The following is a description of a gene set: studied in species Homo sapiens Catalysis of the reaction: carbohydrate phosphate + H2O = carbohydrate + phosphate. Human Gene Set: GOMF_CARBOHYDRATE_PHOSPHATASE_ACTIVITY, and this is the list of marker genes: FBP2, IMPA2, PFKFB2, PFKFB4, FBP1, PFKFB1 (NCBI Gene Id 5207), G6PC3, IMPA1 (NCBI Gene Id 3612), TIGAR, EPM2A, PFKFB3, G6PC2, G6PC1